Given this list of marker genes MAPK3, CALM1, CAMKK2, CREB1, TUBB2A, ACTN2, PRKAA2, GRIN2D, TUBB8B, TUBB4A, PRKAR2A, TUBA3C, CAMK2G, CAMK4, PRKAG3, PRKACG, TUBA3D, CAMK2A, TUBA4A, ERBB4, RAC1, TUBA3E, RPS6KA1, RPS6KA3, TUBA1A, KRAS, DLG4, GRIN2A, PRKAR1A, GRIA2 (glutamate ionotropic receptor AMPA type subunit 2), TUBB6, GRIN1, TUBB8, RASGRF2, TUBAL3, TUBA4B, DLG1, PRKAA1, PRKAG2, GRIA1, CAMK1, TUBA1B, NRGN, PRKAR1B, TUBA8, GRIN2C, DLG2 (discs large MAGUK scaffold protein 2), PRKACA, TUBB1, TUBB2B, NRG1, PRKAG1, NRAS, KPNA2 (NCBI Gene Id 728860), PRKAB2, CAMK2B, CAMK2D, GIT1, PRKAR2B, HRAS, NEFL, MAPT, TUBA1C, PRKX, PRKAB1, RPS6KA2, LRRC7 (NCBI Gene Id 57554), RPS6KA6, TUBB4B, GRIN2B, TUBB3, ARHGEF7, ADCY8, MAPK1, CAMKK1 (NCBI Gene Id 84254), RASGRF1, PDPK1, PRKACB, ADCY1 (adenylate cyclase 1), SRC, DLG3 (NCBI Gene Id 89363), here is a description of the gene set: part of: Activation of NMDA receptors and postsynaptic events species: Homo sapiens Reactome Pathway: Post NMDA receptor activation events Ca2+ influx through the NMDA receptor initiates subsequent molecular pathways that have a defined role in establishing long-lasting synaptic changes. The molecular signaling initiated by a rise in Ca2+ within the spine leads to phosphorylation of Cyclic AMP Response Element binding protein (CREB1) at serine S133, leading to transcription of genes involved in long lasting changes at the synapse. The phosphorylation of CREB1 triggered by increased Ca2+ can be brought about by distinct molecular pathways that may involve MAP kinase, activation of adenylate cyclase and activation of CaMKIV.